The following is a description of a gene set: Type I and type II interferons (IFNs) bind to different cell surface receptors but activate overlapping signal transduction pathways. We examined the effects of a type I IFN (IFN-acon1) and a type II iFN (IFN-g1b) on gene experession in A549 cells and demonstrate that there is a common set of genes modulated by both IFNs as well as a set of gene specifically regulated by each, reflecting the activation of different signaling pathways. In particualr, IFN-g induced many more genes of the signaling pathways, apoptosis, and cytokine interactions than did IFN-a. Even with genes induced by both IFNs there were distinctive quantitativive differences in expression. IFN-g1b plays a major role in the induction and regulation of the complement pathway. Previous work has shown a synergistic antivral and antiproliferative effect of type I and type II IFNs in cell culture and in the treament of tumors in mice. We demonstrate that a majority of genes showed and additive effect of IFN-acon1 and IFN-g1b, but a subset of gene is synergistically induced; these incluce ISG10, MX2, OAS2, and other genes known to be involved in the antiviral response, TRAIL (TNFSF10) and caspases involved in apoptosis and chemokine genes RANTES, CXCL10, and CXCL11. Greater than additive transcription of some of these genes in the presence of both IFNs was confirmed by real-time kinetic RT-PCR. Elevated induction of many of these genes may be sufficient to explain the synergistic antiviral and antitumor effects of this combination of IFNS in vivo. Genes down-regulated in epithelial cells (24h): interferon alpha versus interferon alpha and IFNG. Human Gene Set: GSE5542_IFNA_VS_IFNA_AND_IFNG_TREATED_EPITHELIAL_CELLS_24H_DN from publication Sanda C, Weitzel P, Tsukahara T, Schaley J, Edenberg HJ, Stephens MA, McClintick JN, Blatt LM, Li L, Brodsky L, Taylor MW (PMID 16800785) studied in species Homo sapiens, and this is the list of marker genes: RAB2A, TNKS2, SLN, ZNF25, PIMREG, ARFGEF2 (ADP ribosylation factor guanine nucleotide exchange factor 2), GPSM2, ADAMTS7, HELQ, KIF2C, DCTN5, SGCD, CBFA2T3, IRF2, PARPBP, MINDY1 (NCBI Gene Id 55793), SEC14L1, MYBPC1, KRT39, TIFA, FCAMR, CEP70, ARL3, CDCA8, CDK1, HAX1, ROPN1L, BLOC1S5, C8orf48, TTK, BLVRB, TTF1, CRYBA2, ADHFE1, MARK2 (NCBI Gene Id 2011), PTGR1, RPS6KC1, LIG4, PKP3, NUSAP1, OPTN, SLC25A17, SAPCD2, CDCA3, SSH2, TMEM54 (transmembrane protein 54), RSPH3, PLCG1, IDH2, CTC1, NASP, MRPS31, ZNF518B, MMADHC, KIF23, MRPS26, CLHC1, NDC1, ZNF250, NODAL, PTDSS2, MYL11, SAMD14, TXNDC11, PALM, S1PR4, PCYT1B, SEPTIN1, SLC25A33, MRNIP, AP4M1, PPP6R3, MXD3, TMEM129, MRC2, PFN2, SLC18B1, CEP20, MGAT1 (NCBI Gene Id 4245), CDC14B, NAGK, ZNF496, SNAPC5, CLEC3B, ELMOD3, KRT222, ANKRD55, WASHC3, SORCS1, EXTL1, PRKAR2B, ABCA3, PTGDR, LGALS1, INTS9, GUCA1B, PEDS1, SAMD11, PHF19, ACSF2, ZNF483, TMEM40, CEP89, CHODL (chondrolectin), CYB5R1, MRPL9, TRIM60, TIE1, DPY30, ATP6V0D1, ARL2BP, COMMD2, TMIGD1, FBXO2, ITGB3 (NCBI Gene Id 3690), HMCES, CELF4, IFI27L2, MAN2A1, PITHD1, EPRS1, ENDOU, SAE1, THBS3, TAX1BP3, ACTR10, UBALD2, PRKAG1, IDH3G, TRIR, KDELR1, RAB7A, CDC20, LY6G6D, RACGAP1, CENPF, TERF1 (telomeric repeat binding factor 1), NDC80, SSBP2, SERINC5, FAM149B1, UBTFL1, TPX2, VBP1, PRDM6, ACSS1, CDCA2, CENPP, NEIL1, GDI2, HELB, IGLON5, OSBPL9, RGCC, SLC8A2, TMEM9B, HSPB6, GRPEL2, ITGA6, KPNA2, FCHO1, MTF2, LMO4, ASPM, ZFPM1, POC1A, RITA1, ZNF22, H2AX, LRRC10B (NCBI Gene Id 390205), PSMC3, RFC4, NR4A2, MNAT1, BVES, PSTK (phosphoseryl-tRNA kinase), PRG3, ARHGEF39, KIF18B, DYRK2, INSR, TRAF3IP3, MZB1, CNEP1R1, MKLN1, ARF5, YWHAH, WRAP53, MCUB, MYO1C, ADAMTS1, ZNF746, CYP11B1, CDC25B, ADORA3 (adenosine A3 receptor), SMCO4, NCAPG, FNTA, LGR5, PAFAH1B1